Given this list of marker genes Ubb, Hras, Gab1, Mknk1, Fgf8, Fgf23, Pik3r1, Cbl, Mapk3, Spry2, Fgf1, Fgfr3, Braf, Fgf4, Grb2, Uba52, Fgf2, Fgf18 (fibroblast growth factor 18), Shc1, Ppp2cb, Rps27a, Fgf16, Ubc, Frs3, Fgf5, Fgf9, Fgf17, Fgf20, Frs2, Sos1, Ppp2ca, Galnt3, Uba52rt, Plcg1, Mapk1, Ppp2r1a, Ptpn11, Pik3ca, Kras (Kirsten rat sarcoma viral oncogene homolog), Src, here is a description of the gene set: Signaling by FGFR3 Mouse Gene Set: REACTOME_SIGNALING_BY_FGFR3 studied in species Mus musculus